Given this list of marker genes Pigg, Mppe1, Pyurf, Pgap2, Pigt, Pigh, Dpm1, Pigb, Pigx, Pigw, Cwh43 (cell wall biogenesis 43 C-terminal homolog), Pigs, Pgap1, Pigv, Dpm3, Pign, Pigq, Pigu (phosphatidylinositol glycan anchor biosynthesis, class U), Pigc, Pigl, Gpaa1, Pgap4, Piga, Pigo, Pigp, Pigyl, Pigk, Dpm2, Pigm, Pigf, Slc30a5, Pigz, Pgap3, here is a description of the gene set: Mouse Gene Set: GOBP_GPI_ANCHOR_METABOLIC_PROCESS The chemical reactions and pathways involving glycosylphosphatidylinositol anchors, molecular mechanisms for attaching membrane proteins to the lipid bilayer of cell membranes. Structurally they consist of a molecule of phosphatidylinositol to which is linked, via the C-6 hydroxyl of the inositol, a carbohydrate chain. This chain is in turn linked to the protein through an ethanolamine phosphate group, the amino group of which is in amide linkage with the C-terminal carboxyl of the protein chain, the phosphate group being esterified to the C-6 hydroxyl of the terminal mannose of the core carbohydrate chain. studied in species Mus musculus